Given this list of marker genes Daxx, Srpk2, Aff2, Dyrk3, Sf1, Agap3, Ets1 (NCBI Gene Id 330916), Neat1, Celf3, Uspl1, Malat1, Zpr1, Sumo1, Vrk1, Pml, Habp4, Cdkn2a, Wrap53, Usp50, Serbp1, here is a description of the gene set: studied in species Mus musculus A process that is carried out at the cellular level which results in the assembly, arrangement of constituent parts, or disassembly of any of the extra-nucleolar nuclear domains usually visualized by confocal microscopy and fluorescent antibodies to specific proteins. Mouse Gene Set: GOBP_NUCLEAR_BODY_ORGANIZATION